Given this list of marker genes STXBP6 (NCBI Gene Id 29091), VPS11, STXBP1, LRRK2, SEPTIN8, VPS8, ANKRD27, VPS39, VPS41, VPS16, VPS18, SNCA, PRRT2, VPS33A, TGFBRAP1, here is a description of the gene set: Any process that modulates the frequency, rate or extent of assembly of the SNARE complex. The SNARE complex is a protein complex involved in membrane fusion; a stable ternary complex consisting of a four-helix bundle, usually formed from one R-SNARE and three Q-SNAREs with an ionic layer sandwiched between hydrophobic layers. studied in species Homo sapiens Human Gene Set: GOBP_REGULATION_OF_SNARE_COMPLEX_ASSEMBLY